Given this list of marker genes HSD11B2, TRIM68, IKZF2, VIPR2, ST14, N4BP2L2, TMC2, CFAP20DC, H1-7, ATP2A1, DUSP9, CXCL11, NIPSNAP3A, BACE1, SLC43A2, RPL26, MTMR3, CARM1, KHSRP, HNF1A, CALHM4, PELI2, RPS16, DPP9, ARHGEF3, CYP2E1, CROCC, ENTPD3, H19, CEND1, ADAM33, ANKRD45, ALDH1B1, CHML, SRPX, TPR, AKAP11, CYP7B1, POLR3B, AQR, UBE2U, MEIS1, TCF3, METAP2, NTRK3, OSBPL5, ADAR, ACAT2, TMCO1, CTC1, MOGAT2, PPP1R10, CCDC65, GLB1, CBX7, TRIM59, CDK6, KRT73, HBP1, HLCS, ZNF467, OGDH, IQGAP2, ATG10, ASTN2, ABCB8, LCP2, ZSCAN29 (zinc finger and SCAN domain containing 29), PABPN1L, PLEKHH1, RIMS3, NANOG, HTRA1, SLC23A1 (NCBI Gene Id 9963), VBP1, TTC39A, CLEC7A, AACS, ABCG8, B4GALNT1, NF2, AZIN1, TRHDE, KBTBD12, SNX5, VPS16, KANK4, PROS1, UQCRB, NEUROG2, MAGEF1, PKHD1, CFH, HJURP (NCBI Gene Id 55355), ZKSCAN8P1, ZFP2, LANCL2, SH3TC1, STARD4, SLC16A2, GSAP, TRIM69 (tripartite motif containing 69), AKAP6, HYCC1, TAX1BP1, EIF2AK4, GYS2 (NCBI Gene Id 2998), PTGER4, MTCP1, TIAM1, DHCR7, RPL35, LPIN2, PTCH1, DDX1, PHLDA2, TM4SF20, HDAC6, SCP2D1, DLL1, SAV1, DCC, VNN2, SLCO1A2, IPO5, PNPLA3, RPL11, EZR, PPP3R2, PCDHB15, ERBB2, COMMD10, SLC9A3, C9orf152, NRG4, C4B, C14orf180, TMEM239, BCAS2, GPRC5B, COG5, SIAE, OR51E1, BPIFA1, EYA4, PMEL, CEP192, TMEM230, OR10AD1, COX17, REN, LCA5, GNL3L, RBIS, NRP1, TRPC7, STK32A, NCOA7 (nuclear receptor coactivator 7), ALDH3A1, NUDT17, PGAP6, MSH3, PTPN20, C1orf74, C1orf56, PDE8B, P2RY10, TMC4, ASB15, ZBTB20, SYN3, CYGB, ARMCX1, DCAF1, CSAD, SMOC2, CLCN7, IL9R, SULT2B1, KALRN, CEMIP, HABP2, MAST2, NR0B2 (NCBI Gene Id 8431), MAP2 (microtubule associated protein 2), FAM184B, SLC18A1, ANKRD29, TRIM2 (tripartite motif containing 2), SYT6, SESTD1, DROSHA, MARCHF10, UGP2 (NCBI Gene Id 7360), IP6K3, BCAN, MYLK2, GATA3, PABIR2, here is a description of the gene set: studied in species Homo sapiens Bone marrow-derived macrophages were produced from mice lacking IL-10 alone (IL10-def) or mice lacking both IL-10 and the p50/p105 subunit of NF-kB (p50/IL10), and left unstimulated, stimulated with LPS (1 ng/ml) or stimulated with LPS and IL-10 (0.3 ng/ml). Human Gene Set: GSE19941_UNSTIM_VS_LPS_STIM_IL10_KO_NFKBP50_KO_MACROPHAGE_DN from publication Yang HT, Wang Y, Zhao X, Demissie E, Papoutsopoulou S, Mambole A, O'Garra A, Tomczak MF, Erdman SE, Fox JG, Ley SC, Horwitz BH (PMID 21217011) Genes down-regulated in unstimulated IL10 knockout macrophages versus NFKB1 and IL10 knockout macrophages stimulated by LPS.